The following is a description of a gene set: Any process that modulates the frequency, rate or extent of activated T cell proliferation. Mouse Gene Set: GOBP_REGULATION_OF_ACTIVATED_T_CELL_PROLIFERATION species: Mus musculus, and this is the list of marker genes: Il2ra, Epo (erythropoietin), Cd274, Il12rb1, Igf1, Igf2, Pdcd1lg2, Il4, Rps3, Cd86, Hmgb1, Ager, Tnfsf4, Tnfsf9, Casp3, Pycard, Crtam, Lilrb4a, Il18, Btn2a2, Il12b, Jak3, Cd24a, Stat5b, Scrib, Ppp3ca (NCBI Gene Id 99901), Gpam (NCBI Gene Id 14732), Il23a, Arg1, Laptm5, Prnp, Il2, Fadd, Ido1, Lilrb4b, Stat5a, Lrrc32, Ripk3, Icosl, Igfbp2, Prkar1a, Slamf1, Rc3h1